The following is a description of a gene set: species: Homo sapiens The nucleus of a male germ cell, a reproductive cell in males. Human Gene Set: GOCC_MALE_GERM_CELL_NUCLEUS, and this is the list of marker genes: RAN, SPAG8, TAF3, CCNH, MLH3 (mutL homolog 3), ZMYND15, RAD51, HSPA2, TAF4, H1-9P, KPNA4, PATZ1, TBPL1, BRCA1, LIMK1, TESMIN, TERF2, ADAD1, MLH1, MAEL, CDK2, SMAD5, TOP1, TRIM24 (NCBI Gene Id 8805), TOP2A, TBP, GTF2A1L, TRIP13, HMGA2, AIRE, TCFL5, ACTRT3, ZFPM2, SPATA24, CTCF, SMAD1, DAZAP1, CDK7, RPA1, TNP1, ACTL7A, KDM3A, TAF7, SMARCC1, PCNA, ZBTB16, TERF2IP, ANKRD37, REC8, H2AX, PRM2, SYCP1, MORC1, TSN, TAF10, TOPBP1, STPG4